The following is a description of a gene set: Human Gene Set: GSE9960_HEALTHY_VS_GRAM_POS_SEPSIS_PBMC_DN from publication Payen D, Lukaszewicz AC (PMID 19535937) Genes down-regulated in peripheral blood monocytes (PMBC):healthy versus Gram positive sepsis. To identify signature genes that help distinguish (1) sepsis from non-infectious causes of systemic inflammatory response syndrome, (2) between Gram-positive and Gram-negative sepsis. studied in species Homo sapiens, and this is the list of marker genes: SRGAP2C, CARINH, RSAD2, TNFAIP6, CRLF2, CLEC2D, FZD7, SHFL, IFRD1, ITCH, TVP23A, PPM1K, BHLHE22, TNPO1, ADGRE1, NPTX1, STX17 (syntaxin 17), DNTTIP2, CEP20, JAK3, ST7-AS1, AHR, MN1, IFI27, SAMD9L, NRP2, CXorf65, CARD19, MAP3K13, STAT1, GTPBP4, IFIT2 (interferon induced protein with tetratricopeptide repeats 2), APOO, NSRP1, LILRP2, LRP8, PLAGL1, C1S (NCBI Gene Id 716), OAS2, MALAT1, WHAMM, MIR23AHG (miR-23a/27a/24-2 cluster host gene), CD80, GJB2, RUFY3, MBD2, TRIM14, ACSL5, NAPA, IL7R, CHST2, NET1, OTUD4 (OTU deubiquitinase 4), PRKAG2-AS2, TNFRSF9, NFIL3, EAF1, NFKB2, TNFAIP3, NEURL3, ZWILCH, NFATC2IP, PTGER4 (NCBI Gene Id 5734), TRAF1, CYTIP, CD274, SOD2, LSS, DPYSL2, ETV3, BTBD19, IFIH1, SPATS2L, ISG20, FANCL, NUB1, ALOX15B, G0S2, PIWIL4, METTL1, GCH1, VAPB, LORICRIN, TSPAN33 (tetraspanin 33), IFITM3, PPFIBP2, PCGF5, MIR22HG, NCS1, SLC10A7, CYP27B1, SLC2A6, SLAMF7, MCOLN2, BAALC-AS1, PNPT1 (polyribonucleotide nucleotidyltransferase 1), JAG1, CDS2, IP6K2 (inositol hexakisphosphate kinase 2), PLCB4, INHBA, OAS3, ISG15, EPM2AIP1, MMP14, SPINK5, TRAFD1, TMEM41A, GPR19, PRPF3, DPPA3, DUSP5, MYH10, IL20RB, SEMA4D, ADA, TXN, UBXN2A, PSTPIP2, IFI44, H2BC8, SCP2D1-AS1, RBMXL1, KIF25, GMPR, DOLPP1, SP110, H2BC21, SAMD9, ACOX3 (acyl-CoA oxidase 3, pristanoyl), TNFSF13B, EBI3, ANO2, IFI44L, PALLD, GP1BA, TPD52, TNFRSF4, IRF7 (NCBI Gene Id 3665), SIGLEC1, YJU2B (YJU2 splicing factor homolog B), KLF5, KCNJ2, CFB, SMG1, STAT2, HERC6, CCL5, BTG1, BHLHE40, APOD, APOBEC3B, MMP7, TBC1D10A, NLRC5, DDX60, LHFPL6, SLC25A25, PNRC2, ENSG00000237870, IFITM1 (interferon induced transmembrane protein 1), ZMIZ2, DBF4B, NDE1, IL4R, PASK, MIR3142HG, HYKK, IDO1, PFN1, TCF7, ENSG00000284634, GAK, BRD2, PTTG1, MPHOSPH10, RASGRP1, ADAM32, DUSP22, UBE2Z, RAB35, C15orf48, ENTHD1, EPOP, CELF1, CALHM6, NBN, DNAAF1, HSPB1, RPS6KB1, NADK, BIRC3, TTF1, IDO2, CUL1, LRRFIP2, AK4